The following is a description of a gene set: Human Gene Set: ATF6_01 studied in species Homo sapiens Genes having at least one occurrence of the motif TGACGTGG in the regions spanning 4 kb centered on their transcription starting sites. This matches the ATF6 transcription factor binding site V$ATF6_01 (v7.4 TRANSFAC)., and this is the list of marker genes: KLF13, SH2D2A, TRIM39, PHC1, PER1, SLC22A17, GSC, DNAJB2, STX5, TBX20, RORC, KDELR2, TRPC1, ZFAND5, ICA1, ELF1, HOXB9, LHX1, ZFHX3, SLC39A5, EMSY, XPNPEP1, PRDM12, KLHL22, ERF, SEMA3B, GRIA3, PITX2, EGR1, KCNA6, TMEM263, ERC1, EGR2, KLF9 (NCBI Gene Id 687), SLC39A13, ARMCX2, NPTX1 (neuronal pentraxin 1), EIF4A1, GRB2, PTOV1, SPATA18, GBF1, HCRTR2, ALKBH5, LHX5, TMEM125, TBC1D23 (TBC1 domain family member 23), MADD, PLPP5, TYRO3, KDELR1, SYNCRIP, LRRC59 (leucine rich repeat containing 59), ZFY, IRX3, GNG4, CREM, FLNC, RAB2A, PAX1, BRD2 (NCBI Gene Id 9803), GDNF, JOSD1, LMBRD1, OSBP, SRP19, SP1, GFRA1, STAG1, VCP, TAOK2, TNKS2, LENG9, NANS, DENND5A, WFIKKN2 (WAP, follistatin/kazal, immunoglobulin, kunitz and netrin domain containing 2), SYT11, YPEL4, NKX2-2, COPB1, PAMR1, ARF4, SCYL1, KDELR3, NTRK2, TFE3, DUSP4, USP2, SIK2, STAT3, TPM4, TPT1, TWIST1, GRIN2B, TLE3, SMIM14, SEC23A, SLC35E1, LMX1B, PPP1R10, AMER2, ASPHD1, DLST, SRSF1, TOP1, EGR3, MRPS18B, C1QTNF7, JUND, ETV6, NPAS4, DHX40, LMO4, GPBP1, NOL4, SEC24D, IL1RAPL1, COQ10A, GCC1, ADAMTS3, SEC62, GOLGB1, NR4A1, SLC30A5, RFTN2, TSPAN13